The following is a description of a gene set: electronically inferred by orthology from the curated human pathway This event has been computationally inferred from an event that has been demonstrated in another species.<p>The inference is based on the homology mapping from PANTHER. Briefly, reactions for which all involved PhysicalEntities (in input, output and catalyst) have a mapped orthologue/paralogue (for complexes at least 75% of components must have a mapping) are inferred to the other species. part of: Developmental Biology studied in species Mus musculus Reactome Pathway: Transcriptional regulation of granulopoiesis, and this is the list of marker genes: Cebpa, Cdkn1a (NCBI Gene Id 12575), Cdk4, Rara